Given this list of marker genes EHMT2, SEC22B, LRRK2, SMCR8, TMEM39A, BECN1, SCFD1, FEZ1 (fasciculation and elongation protein zeta 1), NUPR1, PINK1, MTM1, FEZ2, PHF23, here is a description of the gene set: Any process that stops, prevents or reduces the frequency, rate or extent of autophagosome assembly. studied in species Homo sapiens Human Gene Set: GOBP_NEGATIVE_REGULATION_OF_AUTOPHAGOSOME_ASSEMBLY